The following is a description of a gene set: studied in species Homo sapiens Genes up-regulated in macrophages (12h): IFNG and TNF versus IL4. from publication Szanto A, Balint BL, Nagy ZS, Barta E, Dezso B, Pap A, Szeles L, Poliska S, Oros M, Evans RM, Barak Y, Schwabe J, Nagy L (PMID 21093321) Human CD14 positive monocytes were purified from healthy volunteers’ blood and cultured in vitro for 4, 12, 24, 72 hours. While culturing, macrophages were activated alternatively with interleukin-4 (IL-4 100 ng/ml) or classically with interferon-gamma (IFNg 100 ng/ml)+tumor necrosis factor (TNF 50 ng/ml) or left without activation. Simultaneously, macrophages were also treated with vehicle (DMSO:ethanol) or 1mM synthetic PPARg agonist, Rosiglitazone. We used Affymetrix microarrays (U133Plus 2.0) to analyze activation and PPARg-induced gene expression changes. Human Gene Set: GSE16385_IFNG_TNF_VS_IL4_STIM_MACROPHAGE_UP, and this is the list of marker genes: STARD3NL, THNSL1, ERLIN1, CELF4, EXOC7, ZNF516, RBM5, SENP7 (SUMO specific peptidase 7), EIF4E3, CD86, DNAJB14, GNGT2, FHOD1, BCL2A1, KCNK6, FBXO32, KIF1C, LCP1, BLOC1S1, TUBB2A, ECE1, RNF145, RFLNA, GPR26, HRH2, JARID2, GLIS2 (NCBI Gene Id 84662), EPHA1, CX3CR1, CDH16, IST1, DENND3, GPSM3, IVNS1ABP, ATP6AP1, USP45, DYNC1LI2 (NCBI Gene Id 1783), USP12, NCKAP1L, SLC25A11, HIPK2, PIK3AP1, TES, BSND, FCRLA, CRYBG1, GNB4, FEM1C, ESCO1, CIMIP6, EVL, NCOA1, TMEM81, GRAMD2B, SPICE1, AKR7A2, ATOSA, PIP5K1C, LRIF1, GPRC5B, MAP3K14, RPL18A, MTMR6, LACTBL1, EFHD1, VASP, CMTM6, CAPNS1, PYCARD, SLC15A4, RNF123, RPS6KA5, SLC6A3, FMNL2, CBLIF, TMEM127, GLUD1, EPC1, IL34, MARK3, TREML4, SIRPA, WNT11, STX12, SLAMF9, PTPN6, PLEKHG3, SUMF1, CFL1, TRIM7, AKNA, TENT5A, TBC1D1, ABHD12, C5orf47, FAM174A, TAP1, TAOK3, RAB14, MBD2, ZMYM2, CARMIL1, HERPUD1, CRK, MRTFA, TWF2, SLC34A1, GSDMD, MIER2, PPP1R18, MYO9A (NCBI Gene Id 80251), POLB, FBXO11, TNS3, SCRN1 (secernin 1), PRKCB, LIMD1, UBAP1, GDF5, MCUB, HCK, SLC37A3, DGKH, AP2B1, GOLGA1, CTSA, CHFR, MYO9B, PGGT1B, ICOSLG, KRTAP21-1, ITPRIPL2, HLA-E, CDC14A, IRAK2, PTK2, RGS19, ABI3, CEP170B, DEK, MTPN, PCMTD1, CHST15, S100A6, TRAPPC8, CSRNP1, SAMTOR, ITCH, CCND1, ACRBP, FBXL12, DOCK2, ANKH, CREBRF, HAVCR1, FOXRED2, UNC119B, PPFIBP2, SPOP (speckle type BTB/POZ protein), PSMB9, MFHAS1, DCAF7, RTN1, TBK1, ZBTB9, DBN1, MEF2C, SRI, ATP9B, CASP6, HRH1, ZSCAN5B, S100PBP, RTL5, IQGAP1, RRAS2 (NCBI Gene Id 22800), RTN4RL1, PHLDB1, SCAPER, RALA (RAS like proto-oncogene A), ABCA3, PLEKHA5, EIF4A2, VRK2, ARHGAP9, BMPR2, HSPB7, GPATCH2L, ALOXE3, FPR2, PCBP2, PIK3CD, AP3M2, EFHD2, PRDM1, MARVELD1, NR5A1, IRX5, BMP2K, APBB3